Given this list of marker genes Pik3r2, Icosl (icos ligand), Pik3ca, Pik3r3, Pik3cg, Icos, Pik3cb, Pik3r1, Pik3cd, Pik3r6, Pik3r5, here is a description of the gene set: species: Mus musculus Co-stimulation by ICOS Mouse Gene Set: REACTOME_CO_STIMULATION_BY_ICOS